The following is a description of a gene set: The process aimed at the progression of a myotube cell over time, from initial commitment of the cell to a specific fate, to the fully functional differentiated cell. Myotubes are multinucleated cells that are formed when proliferating myoblasts exit the cell cycle, differentiate and fuse. species: Homo sapiens Human Gene Set: GOBP_MYOTUBE_CELL_DEVELOPMENT, and this is the list of marker genes: CACNA1S, SHOX2, DNER, BIN3, P2RX2, IGF1, MYOG, KEL, ACTA1 (NCBI Gene Id 58), SELENON, SPG11, TMEM182, GPX1, SIX1, SKI, SMYD3, HOMER1, PLEC, MYF6, ANHX, XK, NFATC2, DCAF8, ACTN3, HDAC9, COL6A1, CNTNAP1, PPP3CB, NACA, CAV2, KLHL40, WNT10B, STAC3, PPP3CA, SMO, LMOD3, MYF5, MYOD1, RCAN1, LARGE1, FBXO22, BCL2, MYORG, RYR1